Given this list of marker genes ISG20, PLA2G7, MAB21L4, CCR9, HAS3, OAS3, PTPN3, HK2, ULK2, USP37, EPB41L4B, MAST2, VPREB1, ZNF594-DT, KANK4, CSTL1, BPI, SLC8A1-AS1 (SLC8A1 antisense RNA 1), SLITRK5, F13B (coagulation factor XIII B chain), MEFV, PLCB4, RNF217-AS1, BLM, ATP1A4, EPOP, BRINP2, C9orf163 (chromosome 9 putative open reading frame 163), SPMIP9, CRISP1, USP18 (NCBI Gene Id 11274), DCDC2B (NCBI Gene Id 441881), EEIG2, SYNGR1, SERPINF1, PGP, SLC26A10P, INHBA-AS1, RECQL4, FAM162B (NCBI Gene Id 353368), JAK2, POU5F1P3, AKR1C4, KLF5, ZNF197, LINC00313, LONP1, ALG14, SBSN, LCN12, PAPPA2, H2BC14, CXCL13, FOXC1, XRCC2, ZNF19, NUDT16L2P, ENSG00000286546, NPNT, OSBP2, LINC00906, JAKMIP2-AS1, CKB, PMCHL2, CXXC1P1, OR10H3, LINC01530, PCDH18, FAM47A, ARRDC4, PHRF1, SDK2, RANBP17, SLC25A3P1, CXCL3, IL5, ADRA2A, IL2RA, ZBTB32, OAS2, PAH, RANGAP1 (Ran GTPase activating protein 1), COPG2, FKBP4, HERC5, CABS1, SPINK5, POU4F2, PYGL, ITPRIPL1, CYP2S1, ZNF826P, NR4A1, CD209, PRG3, IL12RB2, ILVBL, DOCK8-AS1, MVD, RHEBL1, ARMH1, MICALL2, GSS (NCBI Gene Id 2937), LPO, LAMP3, LDLR, NFIL3 (nuclear factor, interleukin 3 regulated), PI4K2B, TAF5LP1 (NCBI Gene Id 654378), ADGRF1, VEPH1, UBQLNL (NCBI Gene Id 143630), CHID1, MYO1D, UBB, TRAF4, PLAC1, PFKP, PTGFRN, DDAH1, ZNF528-AS1, IRF2BP1, GAS2L3, ZNF667, SPX, LINC02878, CNTN4, FHL5, KCNJ13, BATF, PDE9A, NPM3, HSP90B1, FKBP7, DHCR7, HBB, ZCCHC2, IL1R2 (interleukin 1 receptor type 2), HILPDA, SCN7A, RCC2, MYO5B, ATL1, PPFIA4, STEAP1B (NCBI Gene Id 402466), TESC, PCSK2, SSH3, PDCL2 (NCBI Gene Id 132954), OFCC1, HPYR1, STAR, RANBP3L, ZNF415, NMI, C22orf42, TCOF1, DHCR24, SAMD5, TAP1, CABYR, HHIP, IGF2BP1, CBLN1, ADAMTS19 (ADAM metallopeptidase with thrombospondin type 1 motif 19), SHISA7, CSMD3, SMIM6 (NCBI Gene Id 100130933), FAM47B, SPOCK3, VWA8-AS1, SRSF10, BHLHE40, OR7E156P, GPI, ZG16, TMEM213, KIRREL1, CD276, NEUROD6, MX1, BCL2L14, FEZ1, SLC46A1, SYT1, MAGEA11, RIMS4, LTK, RTN4RL1, SNHG16, RBM47, KITLG, here is a description of the gene set: Genes up-regulated in CD4 cells stimulated with strong dendritic cells (DC) versus CD4 T cells stimulated with weak DCs. from publication Lozza L, Rivino L, Guarda G, Jarrossay D, Rinaldi A, Bertoni F, Sallusto F, Lanzavecchia A, Geginat J (PMID 18081042) The strength of T cell stimulation determines IL-7 responsiveness, recall potential and lineage commitment of primed human CD4+IL-7Rhi T cells. We analyzed how the strength of antigenic stimulation - as determined by dendritic cell (DC) number, DC maturation state and antigen concentration - controls in human CD4+ T cells IL-7R-alpha expression and responsiveness to IL-7, IL-15 and antigen. We found that T cells primed by different strengths of stimulation expressed IL-7R-alpha in different proportions and preferentially on cells that maintained expression of the central memory marker CCR7. However, while CCR7+IL-7Rhi cells generated at high strength of stimulation proliferated vigorously in response to IL-7 or IL-15, CCR7+IL-7Rhi cells generated at low strength of stimulation responded poorly. High cytokine responsiveness was associated with reduced PTEN expression and enhanced s6-kinase activation, consistent with efficient receptor coupling to downstream signalling pathways. Interestingly, while intermediate-stimulated CCR7+IL-7Rhi cells were non-polarized, self-renewed with IL-7 and expanded with antigen, high-stimulated cells generated Th1 effector cells with cytokines but showed impaired IL-2 production and survival with antigen. Gene expression analysis suggested that high-stimulated cells represented pre-Th1 cells with low recall potential and high metabolic state. Taken together these results demonstrate that IL-7 receptor expression and coupling are instructed in T cells by the strength of stimulation and suggest that memory subsets may derive from CCR7+IL-7Rhi precursors that received different strengths of stimulation. species: Homo sapiens Human Gene Set: GSE6566_STRONG_VS_WEAK_DC_STIMULATED_CD4_TCELL_UP